Given this list of marker genes VAX1, EBP, MAPRE2, PIK3CA, ATN1, FOXL2, RNF113A, SNX10, CHD7 (chromodomain helicase DNA binding protein 7), MAB21L2, VPS13B, DKC1, RECQL4, MKS1, GDF3, GJA8, IKBKG (inhibitor of nuclear factor kappa B kinase regulatory subunit gamma), PXDN, MT-CYB, DACT1, FANCL, AP2M1, RREB1, HMX1, HIRA, ASPH, ARHGAP31, MED13L, BUB3, GLI2, TUBGCP6, PIEZO2, RIPK4, PTCH1, ESCO2, AARS1 (alanyl-tRNA synthetase 1), RAB18, LIG4 (DNA ligase 4), OSGEP, PORCN, FANCB, RBP4, ALX3, CENPF, CAPN15, WNT7B, TBX4, PHGDH, TMTC3, SALL4 (spalt like transcription factor 4), ERCC5, TMEM237, NEXMIF, CHD6, SF3B2, BEST1, B3GALNT2, SMCHD1, HCCS, FKRP, DLL4 (delta like canonical Notch ligand 4), NSUN2, KERA, NR4A2, VAC14, CEP120, FANCM, TSPAN12, SRD5A3, ERCC4, FANCE, ZNF699, BMP4, KIF7, FANCF, TCTN1, SEMA3E, RBPJ, SIX3, JAM3, ERCC1, PDGFRB, SOX2, TBC1D20, NUP188, TBX15, FZD5, GJA1, PCYT1A, FREM2, PHYH, ACTG1, KDM6A, MPLKIP, SALL1, POMGNT1, PRR12, PALB2, GLI3, ABCB6, CEP290, GJA5, TKFC, TCTN3, KMT2D, C12orf57, FREM1, FGFR1, SYCE1, TOGARAM1, TCTN2, MED12, PAX2, ALDH1A3, WNT3, NDP, TENM3, MBTPS2 (membrane bound transcription factor peptidase, site 2), NDUFB11, FANCI, FANCG, GTF2E2, TBL1XR1, LAMB2, SMC5, DONSON, POLR1B, SLC25A24, SMG9, FANCA, COX14, RAB3GAP1, BRIP1, ERCC8, TCOF1, RARB, RHOA, LARGE1, POLR1D, POLR1C, FOXC1, SCN1A, NRAS, NAA10, POMT1 (protein O-mannosyltransferase 1), RTTN, SIN3A, SIX6, HMGB3, BCOR, RXYLT1, FIG4, ALX1, POMT2, RPGRIP1L, CEP57, SLC6A1, TMEM98, TMEM107, ERCC3, NHS, LMBRD2, ALDH6A1, FOXC2, BRCA2, ARVCF, ZEB2, XRCC2, B9D1, GDF6, FZD4, TMEM67, FKTN, HDAC6, TOMM7, DPYD, TFAP2A, FANCC, RAX, WDR73, PRIM1, CRPPA, CHUK, YAP1, FGF3, TARS1, RB1, TRIM44, RSPO2, TBCE, VPS35L, RBBP8, PEX7, HYLS1, MAX, RAD51C, MITF, SLX4, KRAS, SLC2A1, VSX2, SPECC1L, SETD5, COL4A1, CHD2, UFD1, UBE2T, PLK4, CTNNB1, EOGT, MED25, GP1BB, TUBB, ERCC2, INTU, XYLT2, SLC38A8, ALX4, CTDP1, ARX, HRAS, PUF60, B9D2, COX7B, KIF11, NOTCH1, PDE6D, GMPPB, RERE, SMAD4, RPGRIP1, FRAS1, FAM111A, MFRP, OTX2, CSPP1, TMEM216, FOXE3, KIF14, WDR37, SHH, PAX6, COMT, TBX1, BUB1, ACTB, MAD2L2, TXNDC15, POMGNT2, POMK (NCBI Gene Id 84197), CRYAA, OCRL, GRIP1, ATOH7, SEC24C, DOCK6, RFWD3 (NCBI Gene Id 55159), INTS1, PRSS56, FANCD2, CARS1, PQBP1, MYRF, LRP5, TBR1, RAB3GAP2, JMJD1C, SYNGAP1, STRA6, TUBGCP4, PIGN, PITX3, SMO, B4GAT1, FBXW11, TRIP13, DAG1, RAD51 (RAD51 recombinase), BRCA1, BUB1B, DNA2, CRB1, TMEM231, GPRASP2, ERCC6, JARID2, KIF15, CC2D2A, GTF2H5, SMOC1, ZNF408, here is a description of the gene set: Microphthalmia Human Gene Set: HP_MICROPHTHALMIA species: Homo sapiens A developmental anomaly characterized by abnormal smallness of one or both eyes.